Given this list of marker genes GOLGA1, ABHD2 (abhydrolase domain containing 2, acylglycerol lipase), DRD1, UNKL, PPP6C, DERL2, REPS2, RAB22A, TAOK1, TMEM100, SPOPL, PRR14L, RASL11B, FAT2 (NCBI Gene Id 2196), VANGL1, BNIP2, ST6GALNAC6, NR2C1, ANKRD17, CXCL6, ZBTB18, PCDH15, BEST3, PCDHA2, SAR1B (NCBI Gene Id 56680), CNOT6L, PPP1R3B, ZNF236, BBX, MKNK2, TOPORS, RLIM (ring finger protein, LIM domain interacting), THRA, TRIM37, UXS1, BCL11B, SCN2B, ZBTB8A, BCL2L11, TRIP11, DNAJC16, C2CD2, MAGI3, ZNF800, F3, EPHA4, REST, USP24, LIMA1, SMAD4, ARMC8, MAP3K8, PDLIM5, EPS15L1, SOS1, STK38, YOD1, NABP1, MAP3K14, AGTPBP1, CLIP4, BTBD10, TRIP10, RGL1, SLC4A8, TSG101, SMOC1, NAPEPLD, SH3PXD2A, LZIC, GUCY1A1, ZSCAN20, NPAS2, PDE3B, KLHL15, CREB1, HYCC2, PAPOLA, CRY2, E2F1, LDLR, TAOK3 (TAO kinase 3), IL1RAP, TBC1D8B, CCDC71L (coiled-coil domain containing 71 like), HPS5, HEG1, TET1, PBX3, SLC22A23, PGM2L1, ETV1, DUSP8, STK17B, U2SURP, KMT2A, OSR1, SERP1, SLITRK3, ZXDA, ARHGAP12, KCNK10, TBC1D20, HSPA8, NRIP3, PITPNA, PCDHA8, PEX5L, DDX5, ZBTB9, NFIB, RRM2, CC2D1A, AKAP11, RGMB, DPYSL5, OXR1, CEP97, BAHD1, UEVLD, ANKRD29, CD274, ARHGEF10, CHD5, NFIC, ENTPD4, SSX2IP, FYCO1, CNRIP1, IQSEC2, PTPN4, ZNF827, PARD6B, ARID4A, FGD4, E2F5, BICC1, KLF9, CHP2, FRMD6, USP31, NR2C2, ANKRD33B, HLF, ABCG4, UBE3C, EZH1, FAM199X, ARHGEF11, UBE2Q2, TET3, FLT1, AGFG2, TRPV6, MAP10, HTR2A, MTMR3, LAMA3, GLIS3, GAB1, PSG3, MKRN1, LYPD6, DENND10, C2orf69, L3MBTL3, RAB5B, TNFAIP1, ITGA4, PLXNA1, SLC17A7, LIMK1, MMP24, KLF11, TMEM265, PAG1, SLC49A4, EIF4A2, IGSF10 (immunoglobulin superfamily member 10), DUSP2, PCDHA12, WDFY2, CSRNP3, MYO5B, GPR6, HECTD2, HAS2, CDC23, ZNF280B, TNKS2, PFKP, APCDD1, NEUROG1, MARCHF8, CREB5, ZNF652, VLDLR, TRAPPC14, EGLN3, URI1, KCNB1, ZBTB21, NKIRAS1, SH3BP5, HIF1A, PPP3R1, SSH2, EEIG1, NBEA, LAPTM4A, IL6ST, BHLHE41, RNASEH2B, GNB5, SEMA4B, RBBP7, CEP120, MTF1, USP6, KMT5B, SRGAP1, BICD2, TMEM167A (NCBI Gene Id 153339), TGFBR2, ARHGEF3, GPATCH2, DOCK4, TPRG1L, EMSY, EGR2, LMO3, USP32, TNKS1BP1, TFAM, PCDHA6, AKAP13, ZFYVE26, RAB11FIP5, ZNFX1, KMT2B, MEX3D, RETREG3, NUP35, ENPP5, KIF3B, TAFA1, MAP7, KIF26B, MIDN, MAPRE3, CNOT4, VSX1, ANKH, SLC16A6 (NCBI Gene Id 9120), FCHO2, KLHL28, NDEL1, CALD1, PRR15, PTPN3, ZFYVE9, CROT, TENM1, PCDHA3, RAB10 (NCBI Gene Id 51140), SESN3, OSTM1, CMKLR1, CHRM2, RORC, ENTREP2, ARHGAP26, CTSA, PAK5, SERF1B, DCBLD2, MAPK4, KIAA1191, NACC2, SLC4A4, UNC80, PPP1R21, CERCAM, PTPDC1, SNTB2, SALL1, TRDN, LRRC55, RBL2, FBXL3, WDR37, FAM210A, DNAJC27, SUCO, FOXK2, ANKIB1, ARID4B, ARHGAP1, GOSR1, TMEM127, SGMS1, P2RX4, ZBTB7A, ZNF367, PKD1, IRF9, BNC2, REEP3, RAB30, MAPK1, ARHGEF18, GABBR2, SIKE1, RASD1, STK11, CLOCK, MCL1, FBXL5, PANX2, TP73, TMBIM6, PCDHA4, PLAG1, AGO1, NCKAP5, EPHA7, MYT1L, CAPRIN2, LRIG1, AKTIP, AAK1 (AP2 associated kinase 1), PCDHA7, DAB2, TMEM138, PIK3R1, RAPH1, NAGK, HAUS8, MAP3K2, FZD3, NIN, ADARB1, FOXJ3, PAPOLB, RNH1, ZBTB20, CAPN15, ELK3, TSPAN9, AMER2, DPYSL2, FAT4, MED12L, RETREG2, PRRG1, OTUD4 (OTU deubiquitinase 4), USP46, OLFM3, FNBP1L, PXK, FBXO48, SNX16, FBXO31, PCDHAC2, ST3GAL1, ERC1, VASH2, PTPRD, PLXDC2, NTN4, B3GALT2, C14orf28, ABHD5, AFG1L, NIBAN1, SEPTIN2, GRAMD1A (NCBI Gene Id 57655), KPNA2, BMPR2, NFAT5, RAP2C, SFMBT1, RGMA, SRPK2, USP28, MFN2, PHIP, DCUN1D1, NHLRC3, TBC1D9, RPS6KA4, PCDHA11, REV3L, RAB11FIP1, GPR63, LHX6, ZBTB4, SLC33A1, CD69, ZDHHC1, PRCP (NCBI Gene Id 5547), ANKRD50, ZFPM2, BRWD1, RPS6KA6, ZDHHC9, ZNF25, STXBP5, RRAGD, FAM13C, PGBD5, STAT3, PLEKHA3 (NCBI Gene Id 65977), SCAMP2, NPLOC4, PKD2, EPHA5, RNF6, CYBRD1, SEMA7A, ZNF148, KIF23, NPAT, LDLRAP1, CFL2, RB1CC1, RACGAP1, SALL3, STYX, ULK1, ISM2, LASP1, USP3, TXNIP, ROCK2, ANKRD13C, RNF128, EREG (epiregulin), GNS, FAM117B, SYTL4, OSM, BRMS1L, XRN1, SLC46A3, PFKFB3, GNPDA2, PDCD1LG2, IRF1, EIF5A2, FGD5, LRPAP1, CMPK1, KLHL2, RAB8B, PURB, ABCA1, SCN1A, ZHX2, FRS2, DENND5B, ERAP1, GPR137C, MCF2L, PRDM6, NCOA3, ITGB8, MFSD8, JPT1, CTSK, ATL3, ELK4, CDC37L1, FBXO21, UNK, AHNAK, SCAMP5, KCNJ10, SLC16A9, SMAD5, FAM13A, ACSL4, MINK1, AGFG1, AP2B1, LRP8, PTPN21, FJX1, ABI1, FNDC3B, EFCAB14, SLMAP, RHOC (ras homolog family member C), WFS1, SSH1, TMX3, MAP3K9, TM2D2, FSD1L, SNX8, SMOC2, LRCH1, NANOS1, MYLIP, KIAA0513, WNK3, MASTL, TMEM64 (NCBI Gene Id 169200), CCND1, WDFY3, OCRL, KAT2B, CCNG2, ZNF264, RORA, PSD, ITPRIPL2, ZNF202, ZNF704, CORO2B, ADAM9, DYNC1LI2, ZC3H12C, ANKFY1, LCOR, SUSD6, RPS6KA5, CMTR2, ATXN1L, DNAL1, SRCIN1, SQSTM1, PCDHA10, PTHLH, CRYBG3, BTG3, TGM2, PHC3, TAGAP, RCCD1, SLC40A1, RSRP1, ZNF597, SAMD12, PCDHA1, CEP170, ZFAND4, ATG16L1, ANO6, HBP1, APP, MYNN, ABL2, SACS, ATP12A, NTNG1, TNFRSF21, MOSMO, CAMTA1, RUFY2, PDGFRA, PLAGL2, SERTAD2, RASGRF2 (Ras protein specific guanine nucleotide releasing factor 2), BTBD7, SOX4, TIAM1, ZBTB41, CENPQ, FEM1C, UBXN2A, NIPA1, TRIM3, DNAJB9, ZNF512B, TRIM36, PRR16, CNOT7, SERF1A, FAM219B, ANKRD52, PCDHA13 (protocadherin alpha 13), SPRED1, NEDD4L, HS3ST5, PTGDR, CNOT6, SLAIN2 (NCBI Gene Id 80106), ATG2B, TANC1, ZBTB33, PCDHA5, STRIP2, NAA30, SLC24A2, S1PR1, RUNX3, ZFP91, PPP1R15B, PCDHAC1 (protocadherin alpha subfamily C, 1), GPR137B, RBL1, GXYLT1, KATNAL1, ORMDL3, LPGAT1, LYST, DDHD1, ARHGEF28, ATAD2, TMEM168, MFAP3L, here is a description of the gene set: Human Gene Set: MIR519D_3P Genes predicted to be targets of miRBase v22 microRNA hsa-miR-519d-3p in miRDB v6.0 with MirTarget v4 prediction scores > 80 (high confidence targets). from publication Chen Y, Wang X (PMID 31504780) species: Homo sapiens